The following is a description of a gene set: Mouse Gene Set: GOBP_DENDRITE_SELF_AVOIDANCE The process in which dendrites recognize and avoid contact with sister dendrites from the same cell. studied in species Mus musculus, and this is the list of marker genes: Cntn6, Emb, Ext1, Prtg, Cntn5 (NCBI Gene Id 620630), Nexn, Myot, Bsg, Nptn (neuroplastin), Mypn, Tnn, Nrcam, Dscaml1, Dscam